Given this list of marker genes DUSP7, DUSP6, MAPK1, PPP2R5D, PPP2CA, VRK3 (NCBI Gene Id 51231), PPP2R1A, PPP2R1B (NCBI Gene Id 5519), MAPK7, DUSP4, DUSP3, PPP2CB, MAPK3, here is a description of the gene set: Reactome Pathway: ERKs are inactivated species: Homo sapiens MAP Kinases are inactivated by a family of protein named MAP Kinase Phosphatases (MKPs). They act through dephosphorylation of threonine and/or tyrosine residues within the signature sequence -pTXpY- located in the activation loop of MAP kinases (pT=phosphothreonine and pY=phosphotyrosine). MKPs are divided into three major categories depending on their preference for dephosphorylating; tyrosine, serine/threonine and both the tyrosine and threonine (dual specificity phoshatases or DUSPs). The tyrosine-specific MKPs include PTP-SL, STEP and HePTP, serine/threonine-specific MKPs are PP2A and PP2C, and many DUSPs acting on MAPKs are known. Activated MAP kinases trigger activation of transcription of MKP genes. Therefore, MKPs provide a negative feedback regulatory mechanism on MAPK signaling, by inactivating MAPKs via dephosphorylation, in the cytoplasm and the nucleus. Some MKPs are more specific for ERKs, others for JNK or p38MAPK. part of: ERK/MAPK targets